The following is a description of a gene set: Mouse Gene Set: REACTOME_AGGREPHAGY Aggrephagy studied in species Mus musculus, and this is the list of marker genes: Dync1i1, Tubb1, Tuba1c, Vim, Ube2n, Dync1h1, Park7, Tuba4a, Dync1li2, Tubb6, Dynll1, Cftr, Prkn, Ubb, Tuba8, Arl13b, Tuba1b, Dync1li1, Dynll2, Uba52rt, Tuba3b, Ubc, Cetn1, Rps27a, Tuba1a, Tubb3, Tuba3a, Tubb2a (tubulin, beta 2A class IIA), Dync1i2, Tubal3, Hdac6, Uba52, Tubb4a, Ube2v1, Tubb4b, Tubb2b